The following is a description of a gene set: Genes predicted to be targets of miRBase v22 microRNA hsa-miR-516b-5p in miRDB v6.0 with MirTarget v4 prediction scores > 80 (high confidence targets). Human Gene Set: MIR516B_5P species: Homo sapiens from publication Chen Y, Wang X (PMID 31504780), and this is the list of marker genes: KNSTRN (NCBI Gene Id 90417), VGLL2, ZNF548, GIPC3, NFAT5, ZFP14, DNAJC25, FNDC5, EGLN3, ADGRL3, MAP7D1, AAK1, CTCF, GRIA2, GJB7, CHAF1B, CFAP157 (NCBI Gene Id 286207), SMC2, LHX9, GGPS1, TLX1, KCNN3, FSD2, SP7, BBOX1, COPS2, DCTD, OTULINL, CFAP44, PCDH7, RBM18, FOXO3 (forkhead box O3), MECP2, SUGCT (succinyl-CoA:glutarate-CoA transferase), EPC1, GYS1 (glycogen synthase 1), TOX3, TMEM183A, LBHD1, CNOT2, SHISA6, PARS2, NPEPPS, KIF4A, DERL2, FRAS1, UPK1B, ARHGEF12, SUMO4, C7orf57, C15orf32, CELF4, SPINK8, COX18, GPR3, GET1-SH3BGR, RIC3, CAPZA1, CFLAR, CACNB2, ADD3, C11orf98, HSDL2, RASSF8 (Ras association domain family member 8), RNF122, SUN2, ITGA9, WARS1, DDAH1, FAM107A, OGFOD1, MYO1B, MTCL3, CHST11, SLIT2, ZNFX1, PJA2, MNT, IL17RE, ANO3, BGLAP, CDK6, TAFA5, LEMD2 (NCBI Gene Id 221496), NCAPG2, CAB39, SYT9, TM9SF3, ZBTB4, GGA3, TMEM183BP, CNNM3, KLHL15, GPR107, ERCC6L2, SRGAP3, OLFML1, CD1A, B3GAT3, YY1, GABRB2, MINAR1, APOLD1, MLLT11, ARMC9, TSPAN33, NAA25, ASB12, FCER2, TPCN1, VTI1A, SH3BGR, CARF, ATM, TMEM240, BACE2, NME6, LIN28B, GXYLT1, RAPH1, HTR1B, SUMO2, MAGI3, RNF20, UBAP2L, VEGFA, ARHGAP5, TSPAN12, KPLCE